Given this list of marker genes Gk2, Fabp6, Gpam, Pnpla5, Gpat2, Dgat2, Agmo, Fabp2 (fatty acid binding protein 2, intestinal), Mogat2, Fabp12, Gykl1, Fabp5, Fabp7, here is a description of the gene set: Reactome Pathway: Triglyceride metabolism species: Mus musculus part of: Metabolism of lipids This event has been computationally inferred from an event that has been demonstrated in another species.<p>The inference is based on the homology mapping from PANTHER. Briefly, reactions for which all involved PhysicalEntities (in input, output and catalyst) have a mapped orthologue/paralogue (for complexes at least 75% of components must have a mapping) are inferred to the other species. electronically inferred by orthology from the curated human pathway